Given this list of marker genes SPAG17, PRR7, LBX1, TSPAN33, GPR162 (NCBI Gene Id 553113), JARID2, EFNA3, ENHO, LTB4R, ABCG4, PHF12, SLC6A9, EDA, EPB41L3, RTN2, NLN, RBMS3, GRK5, CALCR, ITGA5, IL20RB, PCDH17, CREM, CADM2, CA10, STMN4, PHLDB1, ATL2 (NCBI Gene Id 64225), UTP18, PORCN, CPLX1, C22orf31, EXOC6, SLC12A5, TAOK1, C7orf33, LIN7B, FEZF2, HPN, SPRY2, KCNH7, HOXB9, CRLF1, GFAP, DLX1, SPEG, OSTC, MNT, LAD1, ENTPD2, PIP4K2B, PRKAG1, TAOK2, RTKN, TUSC3, IL2RG, KLF13, CDKN1A, OTUB1, YARS1, GNAI2, FXR2, KDM2A, YTHDF2, ADCYAP1, SZT2, PTCH1, UBE2R2, ZFX (NCBI Gene Id 7543), WNT3, HR, LMO3, SHKBP1, SIX4, CORO6, IGFBP5, FOXF2, SPAG9, LDB1, FBRS, HAUS3 (NCBI Gene Id 79441), SORBS1, SGTB, F11R, AMBN, KCNAB3, KLK13, KCNB2, LGI4, HMGN2, LHX4, PLA2G6, PPP1R1B, GNB2, DHRS11, KLHL35, PCBP4, EPHA7, TONSL, PLS3, PRDM16, DLD, LGI1, NIPAL3, TMEM88, KCNK10, LTBR, RCOR2, JUP, TIAL1, MYO1C, YWHAE, SH3GLB2, BRD2, STK16, ASB7, GLB1L, JAKMIP2, EIF1, OTX1, RAP1GAP2, KCND1, MIP, CHRM1, BOC, LIMK2, SRSF5, SEPTIN7, INHA, OTX2, HOXC6, BCL11A, FLNC, EFEMP2, MID2, TMEM8B, REEP1, RARG, RGS6, GIT1, EIF5A, CDC27, DEPDC4, ATP5MC1, USP25 (ubiquitin specific peptidase 25), ZNF384, NHERF1, TRIM33, EIF4E, HIF1A, ANKRD13D, G3BP2, CHD4, RARB, BMP2, PLTP, PTGR3, NTN5, CAMTA2, EPHB2, JPH4, OSM (NCBI Gene Id 5008), PCF11, LRP1, ID3, ZNF532, ADAMTSL1, HRK, BLMH, FGF11, NTN3, AHNAK, CASKIN2, TUG1, SPRY4, DYRK1A, HEXIM2, NECTIN4, PMP22, HAPSTR1, MAPT, BMF, SDC1, NDUFA4L2, SULF1, DIABLO, BEND6, KCNN4, SEMA4C, NINJ2, HOXB8, CITED2, NRG1, CELF4, RGMA, PATZ1, STAG2, GSE1, CNTFR (NCBI Gene Id 1271), ITGB4, HOXC4, HEPACAM2, SKIDA1, TFAP2A, PABPN1, MEA1, RAD23B, ADAMTSL3, CDK4, DCTN1, MORF4L2, SMYD5, MYCL, ADCY5, FOXO4, FKBP2, ADRA2C, C1S, GEMIN7, MTSS1, ABI3BP, CRK, TAGLN, DUSP14, TRIR, XPO1, HES1 (hes family bHLH transcription factor 1), MSL3, SERPINE1, MEIS1, SLC25A23, SHH, GSX1 (NCBI Gene Id 219409), ZCCHC14, PTGDS, MRPL14 (mitochondrial ribosomal protein L14), SP4, TRPV3, MICALL1, LINS1, LHX9, HOXB5, MPC2, RAB30, SLC25A13, CCDC71, MAGEL2, SEMA3B, ETV5, IGF2BP1, LIMD2 (LIM domain containing 2), DENND2D, PI15, KREMEN2, PTPRJ, CDK19, JUND, ZNF296, TMEM35A, GNAO1, EEF1A1, ZHX2, TBL1X, FARP1, GRM3, TP53I11, CALM1, RGS14, CNKSR2, SOX15, KCNH8 (NCBI Gene Id 131096), here is a description of the gene set: Genes having at least one occurrence of the motif CANCCNNWGGGTGDGG in the regions spanning 4 kb centered on their transcription starting sites. This matches the transcription factor binding site V$CACCCBINDINGFACTOR_Q6 (v7.4 TRANSFAC). species: Homo sapiens Human Gene Set: CACCCBINDINGFACTOR_Q6